Given this list of marker genes ARHGEF10, ASH2L, DYRK3-AS1, GSS, DDI2, MIR5695, CHD1, GPR161, CHD2, TMSB15B, RUSC1-AS1, PRELID3B, CUEDC2, TTLL9, COX14, CLDN23, TDP1, DYRK3, COX6B2, SLC35A1, ESR2, PLEKHG2, LINC01596, RUSC1, CCNT1, COPS8-DT, PEX13, RNF19B, ATXN1-AS1, ZNF675, LINC00115, USP18, PTMA, SYCE2, MIR4519, PREX1, STX17, MAST2, MIR3621, TIGAR, TMEM192, WDR83, RCAN2, ENSG00000271860, WDR83OS, GUSBP18, MFNG, ENSG00000215156, PUS10, MIR762HG, FARP1, CHCHD6, RBM34, SCAT1, MARK3, B9D1, SDHAF4, CLIC1, PCSK4, LINC01128, GLIS2, COPS8, EEF1GP4, LINC00240, MAPK7, PHPT1, ZFX-AS1, TENT4A (terminal nucleotidyltransferase 4A, NCBI Gene Id 11044), ZFX, RANGRF, GDF11, MTND5P11, CHD1-DT, MTCO3P12, MMS22L, here is a description of the gene set: Genes containing one or more binding sites for (ZNF582) in their promoter regions (TSS -1000,+100 bp) as identified by GTRD version 20.06 ChIP-seq harmonization. from publication Yevshin I, Sharipov R, Kolmykov S, Kondrakhin Y, Kolpakov F (PMID 30445619) studied in species Homo sapiens Human Gene Set: ZNF582_TARGET_GENES